Given this list of marker genes AMACR, HINT1, SKI, USF2, BSG, C1QTNF12, LMAN2, TSEN15, CMC2, LRIG1, TMEM141, NR1H3, HMOX2, IDH3A, PINK1, XPO7 (exportin 7), GATA1, CDV3, CENPA, HNF1B, RPL39L, ADISSP, MSRB1, PTPRE (protein tyrosine phosphatase receptor type E), AP1M1, CORO1C, TMEM97, TLN1, ARHGAP39, ATXN7L3, IKZF1, TOP2A, RPS6KA4, ZEB1, MXI1, PPP3CB, RAB34, IDH2, MR1, E2F1, PLOD3, ASF1B, AURKB, STK10, CDK9, PECAM1, SLC7A8, PFDN5, FH, ST6GALNAC4, ADCY4, ARRB1, GUCY2D, FRRS1, MME, MRPL41, SMARCD1, IDH3G, SND1, POU2F2, FMNL1, RFC4, PLD3, IMPA2, TUB, DIP2B (disco interacting protein 2 homolog B), COQ5, USP29, MYD88, NUDT9, NCBP2AS2, CCDC93, CYBC1, MGAT1, RCC1, RING1, NME1, INPP4A, XPOT, SOX5, BCL7B, ANKRD13A, BTK, LEFTY1, TBX6, RRBP1, SIRPA, PFDN1, ABCF2, EPN1, EIF2AK4, ACSS1, WDR46, TSEN34, SRPK3, AXL, EPB42, UPF2, SMC3, SLC22A17, TEX9, BZW2, APRT, MKNK1, TBP, ZDHHC14, TOM1, TOPBP1, TNPO2, OR2H1, THRA, TFEB, TTF1, EIF2AK1, HS1BP3, GLMP, TRIM41, CERS2, SYT3, LMO4, DNMT1, SMAP2, FGGY, OXCT1, FLI1, GRN, TLR6, PIP4K2A, CTDSP2, SIRT2, ADGRG3, LAGE3, LGI4, RGL1, ENG, MRPL39, PDXK, DHRS3, NCKAP1L, MPP1, RNF26 (NCBI Gene Id 79102), MITF, MECR, ACP2, CSTF3, CFP, CD48, SPNS1, SRPX, ASIP, CSF1R, FES, USP38, EPB41L2, UGT8, PIK3R1, SH3GL1, GZMM, GNS, GABPA, CLPB, LSM3, KLF2, CERK, NOP10, NPY1R, ATG7, TRIP13, STAG1, FAU, FICD, CLPX, SLC44A2, RPUSD4, MROH1, D2HGDH, APEX1, PLEKHO1, CCL2, RXRA, GNA12, PHRF1, TCF3, EEPD1, PHF23, SLC3A2, STAB1, LIPA, LRPPRC, FGR (NCBI Gene Id 2268), PRKCD, ARPC2, ZFP28, LY9, EVL, PIK3CD, TENM1, PPIH, NCAPH, CENPV, here is a description of the gene set: species: Homo sapiens Human Gene Set: GSE22443_NAIVE_VS_ACT_AND_IL12_TREATED_CD8_TCELL_UP The expansion, trafficking and functional effectiveness of adoptively transferred CD8+ T-cells play a critical role in mediating effective anti-tumor immunity. However, the mechanisms which program the highly proliferative and functional state of CD8+ T-cells are not completely understood. We hypothesized that IL-12, a cytokine commonly induced by TLR activation, could enhance T-cell priming by altering responsiveness to antigen and cytokines. Priming of tumor specific CD8+ T-cells in the presence of IL-12 induced the acquisition of a 'polyfunctional' effector response and increased the generation of memory cells. Moreover, IL-12 priming also promoted high levels of the IL-2 receptor alpha-chain (CD25) and robust IL-2 mediated activation of STAT5. This sensitivity to IL-2 translated into enhanced in vivo proliferation of adoptively transferred CD8+ T-cells. Furthermore, real-time, in vivo imaging of T-cell trafficking confirmed the ability of IL-12 priming to drive in vivo proliferation. IL-12 priming enhanced the anti-tumor function of adoptively transferred cells by reducing established subcutaneous tumor burden, and significantly increasing survival in an established intracranial tumor model. Finally, IL-12 priming of human PBMCs generates tumor specific T-cells phenotypically and functionally similar to IL-12 primed Pmel-1 T-cells. These results highlight IL-12 as an important mediator of CD8+ T-cell effector function and anti-tumor immunity. from publication Lisiero DN, Soto H, Liau LM, Prins RM (PMID 21430221) Genes up-regulated in Pmel-1 CD8 T cells: naïve versus primed with cognate antigen (gp100) and IL-12.